The following is a description of a gene set: species: Homo sapiens Human Gene Set: GOBP_SENSORY_PERCEPTION_OF_MECHANICAL_STIMULUS The series of events required for an organism to receive a sensory mechanical stimulus, convert it to a molecular signal, and recognize and characterize the signal. This is a neurological process., and this is the list of marker genes: TRPA1, KCNQ3, MYO1A, CASP3, LOXHD1, TIMM8B, MIR455, OTOR, GSDME, EYA1, SNAI2, CHD7, HOXA1, KIT, SCN11A, SIX1, CEMIP, MYH14, FZD4, ELMOD3, MIR342, CXCL12, LHFPL3, SERPINE2, DIAPH3, FYN, COL4A3, RIPOR2, TRPV1, USH1C, ATP8B1, STX4, MBP, COL2A1, TMEM120A, GJC3 (gap junction protein gamma 3), GET1 (NCBI Gene Id 7485), SPTBN4, P2RX4, TMC7, TPRN (taperin), BACE1, SPNS2, LRIG1, CCDC50, MYO3B, CLRN1, OTOS, POU4F2, GRXCR1, ASIC2, ADGRV1, GJB6, ZNF354A, CDKN2D, PTPRQ, PHF24, GRM7, EPS8L2, CLIC5, CHRNA9, CHRNB2, TSPEAR, OTOF, SLC17A8, USP53, MYO15A, TMPRSS3, GRAP, LHFPL5, MYO7B, THRB, SOBP, STRC (NCBI Gene Id 1708), ATP6V1B1, CLRN2, SRRM4, PPIP5K2, CLRN3, DIAPH1, NAV2, USH1G, RAB3A, KCNA1, BIRC5, NTRK1, ESPNL, MIR324, DRGX, WHRN, OTOA, COCH, TMTC4, TIMM9, HOMER2, ASIC3, SCARB2, PGAP1, BSND, WFS1, MYO3A, NIPBL, NDUFB9, CABP2, REST, TFAP2A, KCNE1 (NCBI Gene Id 3753), HPN, WDR1, TMEM87A (NCBI Gene Id 25963), LARGE1, MIR762, BARHL1, COL11A2, GJB2, CEACAM16, KCNK2, COL11A1, LRP2, CRYM, UCN, EPYC, USH2A, DDIT3, TRIOBP, PCDH15, PDZD7 (PDZ domain containing 7), CDH23, SERPINB6, ESPN, ATP6V0A4, RPL38, POU3F4, SCN1A, TMIE, SLC1A3, ROR1, CDC14A, EML2, ANKRD24, HEXA, POU4F3, KCNK4, GRXCR2, TIMM10 (NCBI Gene Id 26519), SLITRK6, DCDC2, HEXB, PIEZO2, KIAA0319, FGFR1, ATP2B2, TMEM63B, TBL1X, PKHD1L1, MYO7A, COL1A1, CNTN5, NPR2, HTR2A, NHERF1, AXIN1, TMC1, CHRNA10, CDKN1B, FBXO11, LHFPL4, PAX3, MYO6, MARVELD2, TNF, SLC26A5, OTOGL, ALDH7A1, PJVK, GPX1, SCN9A, TECTA, TBX1, KCNQ1 (potassium voltage-gated channel subfamily Q member 1), TUB, SLC26A4, MYC, MINAR2, POMGNT1, TMC2, TIMM13, COL6A1, P2RX2, MKKS, LRIG2 (leucine rich repeats and immunoglobulin like domains 2), KCNQ4, SLC52A3, ITGA2, SPRY2, CACNA1D, SOD1